The following is a description of a gene set: Human Gene Set: HP_CHOROIDEREMIA studied in species Homo sapiens Choroideremia, and this is the list of marker genes: PRPH2, BEST1, IMPG1, CHM, POU3F4, EPHA2, UBE3B, IMPG2